The following is a description of a gene set: electronically inferred by orthology from the curated human pathway Reactome Pathway: Phase I - Functionalization of compounds part of: Biological oxidations studied in species Mus musculus This event has been computationally inferred from an event that has been demonstrated in another species.<p>The inference is based on the homology mapping from PANTHER. Briefly, reactions for which all involved PhysicalEntities (in input, output and catalyst) have a mapped orthologue/paralogue (for complexes at least 75% of components must have a mapping) are inferred to the other species., and this is the list of marker genes: Cyp26a1 (NCBI Gene Id 13082), Cyp2a4, Cyp4f15, Nr1h4, Cyp3a41a, Mtarc2, Cyp3a13, Cyp24a1, Nqo2, Cyp2e1, Cyp2c66, Fdx1, Cyp1a1, Aldh3a1 (aldehyde dehydrogenase family 3, subfamily A1), Ces3a, Pomc, Cyp4a10, Cyp3a44, Cyb5b, Fdxr, Cyp4a31, Fmo1, Cyp8b1, Cyp4f18, Cyp4f40, Cyp3a41b, Cyp4b1, Cyp2a12, Cyp2f2, Ces2h, Ncoa1, Cyp2c65 (cytochrome P450, family 2, subfamily c, polypeptide 65), Cyp2d22, Cyp1b1, Cyp2j6, Cyp46a1, Cmbl, Cyp4f39, Mtarc1, Cyp1a2, Aoc3, Ptgis (NCBI Gene Id 19223, prostaglandin I2 (prostacyclin) synthase), Cyp3a11, Aldh2, Adh4, Arnt2, Adh5, Cyp2c55, Fdx2, Cyp39a1, Cyp11b2, Cyp4a12a, Cyp3a16, Cyp51, Cyp2u1, Ces1d, Cyp4a29, Ces3b, Aoc2, Aldh1b1, Cyp3a57, Cyp4v3, Cyp4a30b, Cyp19a1, Tbxas1, Cyp3a25, Ptgs1, Cyp26b1, Cyp7a1